Given this list of marker genes LGI1, KCNT1, SCN8A, MICAL1, RELN, PDE2A, KCNQ3, PRRT2, DEPDC5, GAL, KCNQ2, here is a description of the gene set: species: Homo sapiens Focal autonomic seizure An autonomic seizure is a type of focal non-motor seizure characterized by alteration of autonomic nervous system function as the initial semiological feature. Human Gene Set: HP_FOCAL_AUTONOMIC_SEIZURE